Given this list of marker genes Nipbl, Smc3, Elk1, Gli3, Smc1a, here is a description of the gene set: Binding to a mediator complex. The mediator complex is a protein complex that interacts with the carboxy-terminal domain of the largest subunit of RNA polymerase II and plays an active role in transducing the signal from a transcription factor to the transcriptional machinery. The Saccharomyces complex contains several identifiable subcomplexes: a head domain comprising Srb2, -4, and -5, Med6, -8, and -11, and Rox3 proteins; a middle domain comprising Med1, -4, and -7, Nut1 and -2, Cse2, Rgr1, Soh1, and Srb7 proteins; a tail consisting of Gal11p, Med2p, Pgd1p, and Sin4p; and a regulatory subcomplex comprising Ssn2, -3, and -8, and Srb8 proteins. Metazoan mediator complexes have similar modular structures and include homologs of yeast Srb and Med proteins. species: Mus musculus Mouse Gene Set: GOMF_MEDIATOR_COMPLEX_BINDING